The following is a description of a gene set: studied in species Homo sapiens Human Gene Set: GOMF_7SK_SNRNA_BINDING Binding to a 7SK small nuclear RNA (7SK snRNA)., and this is the list of marker genes: HEXIM1 (HEXIM P-TEFb complex subunit 1), DDX21, CDK9, CCNT1, HEXIM2, MEPCE, CELF3, LARP7, CCNT2